Given this list of marker genes Hsp90aa1, Foxo3, H4c17, Kat2b, Polr2d, Greb1, Tgfa, Cav1, Tbp, Polr2c, H2bc9, Hbegf, Usf1, Ppp5c, Cav2, H4c6, Pik3r1, Gnb4, Gnat3, Egf, Polr2b, Mmp9, Gng10, Carm1, Mapk1, H4c18, Akt2, H2bc26, Nos3, Gng4, Ddx5, H2bc13, H2bc14, H4c9, Uhmk1, Gnai3, H2bc23, H3c2, Pik3r3, Calm2, H4c2, H3c1, H3c7, Calm1, Gtf2f1, Ncoa1, S1pr3, Calm3, Esr2, Gnai2, H4c4, Sp1, H2bc22, Egfr, Shc1, Tle3, Usf2, Strn, H3c10, Hsp90ab1, H2bc11, H3f3b, H3f3a, Polr2a, H3c15, Gng2, Xpo1, Gng7, H2bc7, H3c4, Mmp2, Epgn, H4c16, Pik3ca, H2bc15, Polr2e, Fkbp4, Creb1, H3c14, Pdpk1, Polr2g, Esr1, H4c11, Ep300, Gng3, H4c8, H3c13, Fkbp5, Cdk9, Akt1, H2bc3, H2bc1 (NCBI Gene Id 319177), Cbfb, H4c12, Hras, Areg (NCBI Gene Id 11839), H3c8, Gata3, Foxa1, Erbb4, Mmp7 (matrix metallopeptidase 7), Gnb1, Zdhhc7, Mmp3, Gnb2, H2bc12, Polr2i, Ereg, Src (NCBI Gene Id 99351), Ccnt1, Gng8, Gnai1, Polr2f, Pik3r2, Gng5, H2bc24, Ptges3, Zdhhc21, Ncoa2, Sphk1, H2bc8, H4c1, Gngt1, Gng12, Cited1, Hspb1, Gng13, Ptk2, Igf1r, Polr2l, Gtf2a2, Prkcz, Btc, H2bc21, H3c11 (NCBI Gene Id 319153), H3c6, Gng11, Kat5, Gnb5, Polr2h, Gtf2a1, Polr2k, Gngt2 (NCBI Gene Id 14710), Kras (Kirsten rat sarcoma viral oncogene homolog), Nrip1, Gtf2f2, Med1, H3c3, H2aj, Kdm1a, Cdkn1b, H2bc6, Gnb3, Akt3, H2bc4, H4c3, Prmt1, Pgr, H4c14, here is a description of the gene set: studied in species Mus musculus Mouse Gene Set: REACTOME_ESR_MEDIATED_SIGNALING ESR-mediated signaling